The following is a description of a gene set: studied in species Mus musculus The covalent alteration of one or more fatty acids in a lipid, resulting in a change in the properties of the lipid. Mouse Gene Set: GOBP_LIPID_MODIFICATION, and this is the list of marker genes: Por, Gba2, Dgke, Acox1, C1qtnf9, Gba1 (NCBI Gene Id 14466), Hsd17b4, Echdc2, Mtmr1, Pten, Fig4, Auh, Acacb, Abcc9, Cyp3a16, Pla2g7, Abo, Acat1, Ggta1, St3gal2, Synj1, C1qtnf2, Aldh1l2, Irs2, Dbi, Acaa1b, Mboat7, Ech1, Ocrl, Hadh, Samd1, Acadvl, Plppr3, Plppr2, Pex5, Adipor2, Glt6d1, Mboat2 (NCBI Gene Id 67216), Dgkq, Acad12, Acaa2, Mtmr2, Plppr4, Inpp5j (NCBI Gene Id 170835), Ppara, Mtmr7, Plin5, Inpp5b, Plpp2, Mtmr9, Echdc1 (NCBI Gene Id 66937), Alox12e, Acadm, Gbgt1, Sesn2, Sox9, Fmo4, Cpt1a, Alox5, Inpp5e, Alox8, Cyp4v3, Appl2 (adaptor protein, phosphotyrosine interaction, PH domain and leucine zipper containing 2), Slc27a2, Dgat2, Dgkb, Akt2, Nucb2, Plppr1, B4galnt1, Etfa, Ehhadh, Pdk4, Dgkh, Acox2, Fa2h, Adh7, Slc25a17, Porcn, Lpcat3, Mlycd, Plppr5, Ilvbl, Sgpp2, Mtmr12, Abcd2, Abcd3, Hadhb, Cnr1, Adipoq, Alox12b, Hao1, Pip4p2, Fmo1, Mboat1, Adh5, Sacm1l, Plpp1, Mtmr11, Inppl1, Crot, 4930568D16Rik, Pex2, Inpp5f, Plpp3, Decr1, Abcb11, Prkaa1, Mir199a-2, Sirt4, Acads, Abcd1, Mtmr10, Acoxl, Alox15 (arachidonate 15-lipoxygenase), Irs1, Bdh2, Cyp1a1, Cyp3a41a, Scp2, Inpp5a, Acsbg2, Fmo2, Apod, Acsl5, Abcd4 (NCBI Gene Id 19300), Inpp5d, Dgat1, Acad11, Cyp3a44, Fabp3, Ppard, Hadha, Klhl25, Mboat4 (membrane bound O-acyltransferase domain containing 4), B4galnt2, Gdf15, Lonp2, Mapk14, Cpt1b, Obp2a, Mir214, Cygb, Etfbkmt, Plpp6, Ppargc1a, Agk, Gcdh, Pex7, A3galt2, Hsd17b10, Cp, Mtmr3, Cpt2, Pparg, St3gal4, Eci1, Adipor1, Acaa1a (NCBI Gene Id 52057), Akt1, Cyp2e1, Mtmr6, Hao2, Cyp3a41b, Eci3, Plpp4, Blvra, Ivd, Dgkg (NCBI Gene Id 73000), Adh4, 4930402F06Rik, Acad10, B3galt1 (NCBI Gene Id 70755), Etfb, Synj2, Fabp1 (fatty acid binding protein 1, liver), Crat, Cyp3a11, Sgpp1, Pip4p1, Mtm1, Rnf213, Inpp4b, Dgka, Pex13 (peroxisomal biogenesis factor 13), Dgkd, Cyp4f13, Tysnd1, Eci2, Phyh, Dgki, Twist1, Ephx2, Mtmr4, Etfdh, Dgkz, Alox12, Hacl1, Slc35c1, Acox3, Mtor, Aloxe3, Plpp5, Echs1, Acadl, Mtln, Chrm5, Inpp5k, Mfsd2a (MFSD2 lysolipid transporter A, lysophospholipid), Lep